The following is a description of a gene set: Human Gene Set: HARALAMBIEVA_PBMC_TIV_AGE_50_74YO_CORRELATED_WITH_MEMORY_B_CELL_RESPONSE_28DY_NEGATIVE from publication Haralambieva IH, Ovsyannikova IG, Kennedy RB, Zimmermann MT, Grill DE, Oberg AL, Poland GA (PMID 27317456) BACKGROUND: Studies suggest that the recall-based humoral immune responses to influenza A/H1N1 originates from activated memory B cells. The aim of this study was to identify baseline, early and late blood transcriptional signatures (in peripheral blood mononuclear cells/PBMCs) associated with memory B cell response following influenza vaccination. METHODS: We used pre- and post-vaccination mRNA-Seq transcriptional profiling on samples from 159 subjects (50-74years old) following receipt of seasonal trivalent influenza vaccine containing the A/California/7/2009/H1N1-like virus, and penalized regression modeling to identify associations with influenza A/H1N1-specific memory B cell ELISPOT response after vaccination. RESULTS: Genesets and genes (p-value range 7.92E(-08) to 0.00018, q-value range 0.00019-0.039) demonstrating significant associations (of gene expression levels) with memory B cell response suggest the importance of metabolic (cholesterol and lipid metabolism-related), cell migration/adhesion, MAP kinase, NF-kB cell signaling (chemokine/cytokine signaling) and transcriptional regulation gene signatures in the development of memory B cell response after influenza vaccination. CONCLUSION: Through an unbiased transcriptome-wide profiling approach, our study identified signatures of memory B cell response following influenza vaccination, highlighting the underappreciated role of metabolic changes (among the other immune function-related events) in the regulation of influenza vaccine-induced immune memory. Genes negatively correlated with memory B cell response in peripheral blood mononuclear cell in adults (50-74) after exposure to trivalent inactivated vaccine (A/California/7/09 (H1N1,), A/Perth /16/2009 (H3N2), and B/Brisbane/60/2008)., time point 28D. Comment: Association of baseline, early and late gene expression changes with peak memory B cell ELISPOT response (Day 28 - Day 0) in older individuals species: Homo sapiens, and this is the list of marker genes: ZNF32, CMBL, NECTIN3-AS1, CFH, IGSF9B, KIAA0408, MCRIP1, MSX2P1, TTLL1, NDFIP2, KRT1, TRIM2 (tripartite motif containing 2), SELENOW, UGP2, BLCAP, CNPY4, ITGB1BP1, SERGEF, DHRS13, PECR, STX8, ERG28, LINC02591, GOLGA7B, CHMP4A